Given this list of marker genes Scn4a, Scn8a, Hcn3, Hcn1 (NCBI Gene Id 319874), Scn4b, Tpcn1 (NCBI Gene Id 338536), Scn2b, Cacna1h, Scn5a, Scn9a (sodium channel, voltage-gated, type IX, alpha), Hcn4, Scn2a, Scn11a, Nalcn, Cacna1i, Scn3b, Cacna1g, Scn3a, Asic2 (NCBI Gene Id 637557), Hcn2, Scn1b, Pkd2, Scn10a, Scn1a, here is a description of the gene set: species: Mus musculus Mouse Gene Set: GOMF_VOLTAGE_GATED_SODIUM_CHANNEL_ACTIVITY Enables the transmembrane transfer of a sodium ion by a voltage-gated channel. A voltage-gated channel is a channel whose open state is dependent on the voltage across the membrane in which it is embedded.